Given this list of marker genes TMBIM1, TNF, SCRT2, BCLAF1 (NCBI Gene Id 9774), SFRP1, PAK2, ATF4, ATAD5, CAV1, BBC3, INHBA, SYVN1, MIR16-1, FEM1B (NCBI Gene Id 23374), FAF1, IER3, ACVR1, S100A9, MTCH2, MIR142 (microRNA 142), TNFSF10, RAF1, SNAI2, HSPA1B, MADD, PELI3, DAB2IP (DAB2 interacting protein), AR, SFPQ, PTPMT1, SEPTIN4 (septin 4), CTSC, COL2A1, TNFSF12, TPD52L1, CD74, PEA15, PLAUR, NHERF1, BRCA1, TNFAIP3 (NCBI Gene Id 7128), CTTN, CREB3L1, IFI6, BAD, HTRA2, SGMS1, TMBIM6, FGF2, SLC25A4, RPS7, CD40LG, PRKN (parkin RBR E3 ubiquitin protein ligase), ACKR3, HSPB1, GSTP1, NOX1 (NADPH oxidase 1), NACC2, URI1, SP1, MIR186, SKIL, MIR221, TAF6, MAP2K1, ICAM1, DDIAS, MIR27B, SOD1, IL19, PHIP (NCBI Gene Id 83843), HELLS, GCLC, PCGF2, RET, MIF, MIR92A1, TRIM32 (NCBI Gene Id 3971), SGK3, HNRNPK, TAF9B, BMP5, SERPINE1, MPV17L, PPEF2, APP, EPO, STRADB, BMPR1B, FGF10, FCGR2B, BMI1, LTB, TNFSF11, PRKRA, MAL, LMNA, STK3, PINK1, PLAGL2, CDKN2D, MIR133A1, PDIA3, LGALS3, MIR15A, DDX3X, MIR195, SH3RF1, GATA1, TAF9, BCAP31, LCK, RAD9A, TGFB2, BCL2L1, TNFRSF12A, RFFL, ERP29, GATA4, VNN1 (vanin 1), ACSL5, HTT, NME5, TRAF7, ZMYND11, PRELID1, RELA, HGF, FZD1, FGG, LRRK2, TCF7L2, GCLM, WNT1 (Wnt family member 1), EYA4, FIS1, BAX, MAPK8IP1, SERINC3, TP53BP1, BDNF, JAK2, KDM1A, SLC25A31, PTPN2, TLR6, MAGEA3, EIF2AK3, FBH1, ZNF385A, CFLAR, TP53, FLCN, CTNNB1, NRG1, TP63, RIPK1, WNT16, DEPTOR, PTGS2, ASAH2, FIGNL1, PARK7, NFE2L2, CTH, MUC1, CD44, THBS1, CCAR2 (NCBI Gene Id 57805), MIR29B1, TRAP1, CSF2, NR4A2, OPA1, GHITM, TRAF2, FBXO7, ITGAV, TMEM161A, PTPRC, HSF1, TERT, SIAH1, MIR21, MAGED1, TIFAB, YBX3, BOK, RIPK3, IFNB1, CRADD, SRPX, ING2, IKBKG, STK4, MIR210, ITM2C, GRINA, PARP1, NF1, PTTG1IP, PTPN1, MAPK8IP2, HMOX1, TRIAP1, BCL10, CTSH, NGFR, FGA, MYC, SLC25A5, RNF34, PIK3CB, FBXW7, ADCY10, CXCL12 (NCBI Gene Id 6387), CSNK2A2, PRODH (proline dehydrogenase 1), SRC, S100A8, STX4, MARCHF7, MMP2, MNT, KLF4, IVNS1ABP, MIR17, LTBR, SIAH2, PSME3, MAZ, BCL2L11, ING5, ARMC10 (armadillo repeat containing 10), DAPK2, RB1CC1, HYOU1, PYCARD, CASP2, SLC35F6, CX3CR1, MIR199A1, YAP1, HSPA1A, LTA, ELL3, AGTR2, TRIM39, FAIM, TPT1, FGB, NCK2, TP73, INS, BAG5, RPS6KB1, PPP1CA, SP100, NOG, DNAJA1, SNAI1, ACAA2, APAF1 (NCBI Gene Id 317), WFS1, MDM2, MMP9, PYCR1, NONO, PMAIP1, HMGB2, AATF, RRM2B, NOL3, FZD9, NCK1, PDX1, MIR26B, MAPK7, AKT1, MCL1, P4HB (prolyl 4-hydroxylase subunit beta), GFRAL, SCG2, PPARG, GNAI2, HYAL2, NANOS3, IL20RA, DDIT3, SOD2, STYXL1, CYLD, NOC2L, INCA1, RB1, MIR132, ENO1, RTKN2, FAS, RPL26, WNT5A, FASLG, PSMD10, EIF5A, EEF1E1, WWOX, RPS3, SELENOS, USP47, TNFSF15, ITPRIP, PARL (presenilin associated rhomboid like), IL7, SLC25A6, FADD, CREB3, DEDD2, NKX3-1, DBH, EYA2, PPP2R1B, IL10 (NCBI Gene Id 3586), BIRC6, PML, PRKCD, IL1B, PIAS4, BDKRB2 (bradykinin receptor B2), GPX1, UNC5B (NCBI Gene Id 23663), EYA3 (EYA transcriptional coactivator and phosphatase 3), NRP1, ZSWIM2, RACK1 (receptor for activated C kinase 1), NOS3, FGFR1, SFRP2, WNT4, CTNNA1, PSEN1, ATF3, ADORA2A, TRAF1, MIR19A, FXN, UBB, TLR4, G0S2, GSDME, RNF183, RRN3, BECN1, TREM2, PPIF, CX3CL1, C8orf44-SGK3, IL1A, IGF1, TNFSF14, BAK1, PPIA, UBQLN1, SIRT1, GPER1, BMP4, BCL2L14, HDAC1, RBCK1, QARS1, MSX1, PAK5, MIR449A, XBP1, MIR146A, BCL2, INHBB, PRDX2, HIGD1A, USP15 (ubiquitin specific peptidase 15), EI24, BID, HERPUD1, TMEM14A, NUPR1, PPP2R1A, MAP2K5, AGT, EYA1, ARHGEF2, HIF1A, TXNDC12, NFATC4, GSK3B, CSNK2A1, MAPK9, ITGA6 (NCBI Gene Id 3655), TMC8, GDNF, CLU, MIR222, FAIM2, PF4, BCL2L12, FYN, TGFBR1, here is a description of the gene set: studied in species Homo sapiens Any process that modulates the frequency, rate or extent of apoptotic signaling pathway. Human Gene Set: GOBP_REGULATION_OF_APOPTOTIC_SIGNALING_PATHWAY